The following is a description of a gene set: species: Homo sapiens Any process that modulates the frequency, rate or extent of germ cell proliferation. Human Gene Set: GOBP_REGULATION_OF_GERM_CELL_PROLIFERATION, and this is the list of marker genes: HPGDS, PRDX4, PTGDS, FANCA, RHBDD1, PTGDR2, CIB1